Given this list of marker genes Nolc1, Fbll1, Exosc6, Exosc3, Dkc1, Nudt16, Nudt16l2, Exosc10, Parn, Rnf113a2, Fbl, Tent4b, Larp7, Exosc2, Nudt16l1, Exosc4 (exosome component 4), Zcchc7, Rnf113a1, Exosc5, Larp7-ps, here is a description of the gene set: The chemical reactions and pathways involving snoRNA, small nucleolar RNA, any of a class of small RNAs that are associated with the eukaryotic nucleus as components of small nucleolar ribonucleoproteins. They participate in the processing or modifications of many RNAs, mostly ribosomal RNAs (rRNAs) though snoRNAs are also known to target other classes of RNA, including spliceosomal RNAs, tRNAs, and mRNAs via a stretch of sequence that is complementary to a sequence in the targeted RNA. Mouse Gene Set: GOBP_SNO_S_RNA_METABOLIC_PROCESS studied in species Mus musculus